Given this list of marker genes Bfar, Ddrgk1, Dnajb9, Hspa5 (NCBI Gene Id 99198), Pdia6, Ufl1, here is a description of the gene set: Mouse Gene Set: GOBP_NEGATIVE_REGULATION_OF_IRE1_MEDIATED_UNFOLDED_PROTEIN_RESPONSE studied in species Mus musculus Any process that stops, prevents or reduces the frequency, rate or extent of the IRE1-mediated unfolded protein response.